The following is a description of a gene set: studied in species Homo sapiens Heterotropia Human Gene Set: HP_HETEROTROPIA Manifest deviation of the visual axes not controlled by fusion., and this is the list of marker genes: HNRNPH2, HUWE1, NTNG2, ALG2, MED12, SOX5, VSX1, U2AF2, ADNP, EFNB1, PIGL, SLC6A8, EXOC8, SLC38A8, HERC2, ATAD3A, GTF2H5, HADHA, FZD4, UFSP2, SNRPN, WT1, EXOSC8, SCO2, CLCN6, OFD1, TUBB2B, PIGV, TRIT1, TYR, TOPORS, MPDZ, FGFR3, PURA, AIMP1 (aminoacyl tRNA synthetase complex interacting multifunctional protein 1), KCNMA1, ARHGAP31, SREBF1, MKRN3, PIK3R1, GALC, ADAT3, ALG9, AGRN, ERCC2, SLC32A1, CACNA1F, SON, FRMD5, RERE, NCDN, PCDHGC4, EXOSC9, MAGEL2 (NCBI Gene Id 54551), SMAD3, PIGY, HMGB3, CDKL5, SLC18A3, PIGO, KIDINS220, MYO9A, ZEB2, COL4A1, LGI4, CDC42BPB, SNORD115-1, KDM6B, RTL1, ROBO3, FBXO28, H4C11, NMNAT1, HOXB1, TBC1D23, AHDC1, SLC25A46, ACADSB, HPS3, WDR45, LRP5, KIF21A, AP1G1, MEG3, RNASEH1, GTF2E2, PHGDH, CBS, GRHL2, RNF2, ERCC3, SLC35A2, FGF10, GRID2, OVOL2, TMEM231, ATP1A2 (NCBI Gene Id 93186), CAMK2B, TMEM216, DPM1, AMMECR1, ABCC9, RRAS2, PEX5, LRAT, COL6A2, BLOC1S3, CLCN3, GLRB, COL25A1, PTEN, GNB2, SNORD116-1, TTI1, PIGW (phosphatidylinositol glycan anchor biosynthesis class W), PRR12, PPP2R5D, CRELD1, PDE4D, PRKAR1B, SOBP, POU4F1, PPP1R21, CYB5A, LCA5, MRPS34, CHD8, PIDD1, ATOH7, UBE3A, SYT1, ARPC4, PWRN1, CLP1, POLA1, NONO, GNA14, KIF7, IRF2BPL, CARS1, PYROXD1, COL6A3, MPLKIP, CRIPT, LYRM7, CHMP1A, POLRMT, LMNB1, NEUROD2, NEXMIF, COL8A2, ANKH, TGFBR1, RNF113A, NSD1, SEC23A, PIGT, PGAP3, SLC25A1, MC1R, KDM1A, FGFR2, SALL2, FAM149B1, GALNT2, TCTN3, CYB5R3, DPP6, CRB1, SLC12A6, ADGRG1, SPATA7, FBXW11, ITPR1, COL12A1, MBD5, TUBB3, KAT8, PWAR1, CHST3, SLC1A3, UBAP2L, PGAP2, EBP (NCBI Gene Id 139151), AARS1, PGM2L1, APC, COL13A1, POGZ, RPGRIP1, H4C5, USP7, DYRK1A, TENM3, FBN1, DLK1, TBC1D2B, EXOSC5, HPDL, UFC1, SLC17A5, RRM2B, AGTPBP1, COG8 (component of oligomeric golgi complex 8, NCBI Gene Id 84342), THOC2, RORA, VRK1, MADD, PHOX2A, PRPS1, LRPPRC, AHCY, TRPM3 (NCBI Gene Id 80036), EIF4A2, PIGN, RPE65, TBCK, DNMBP, CACNA1A, TBX1, DDOST, GNB1, SOST (NCBI Gene Id 8149, sclerostin), MYF5, DPAGT1, BCOR, COL4A2, RP1L1, SIAH1, ATP1A3, PYCR2, SLC5A7, CPLANE1, OCA2, PUF60, NGLY1 (NCBI Gene Id 95041), PAX6 (paired box 6), CDC42, B3GAT3, ANTXR1, MYOD1, ZEB1, TUBA1A (tubulin alpha 1a), BCORL1, ADD3, COL11A1, SNAP25, KIAA0753, WARS2, ADARB1, CHAT, P4HTM, KAT6A, VAMP1, RPL10, IARS2, NALCN, NPAP1, TMEM67, GBA1, POLG (NCBI Gene Id 5428), NR2F1, EXOSC3 (NCBI Gene Id 51010), TAF2, SYT2, LRMDA, LAGE3, TARS1, TGFBR2, WDR11, ZC4H2 (NCBI Gene Id 7493), COL6A1, LMBRD2, ATRX, ZSWIM6, EMC1, PMM2, PDE6D, PTRH2, GRM1, UNC80, ALDH3A2, ATIC